Given this list of marker genes Ncf2, Nudt12, Nudt13, Ncf1, Nudt17, here is a description of the gene set: studied in species Mus musculus The chemical reactions and pathways resulting in the breakdown of nicotinamide adenine dinucleotide phosphate (NADP+), a coenzyme that interconverts with its reduced form, NADPH, in many redox and biosynthetic reactions. Mouse Gene Set: GOBP_NADP_CATABOLIC_PROCESS